Given this list of marker genes Naglu, Fgfr2, B4galnt1, Fgf8, Taf10, Pkdcc, Intu, Lrp4, Kdf1, Med31, Gli2, Wnt7a (NCBI Gene Id 22421), Nfia, Bmp4, Psen2, Rax, Wdr19, Hottip (NCBI Gene Id 791364), Cyp26b1 (cytochrome P450, family 26, subfamily b, polypeptide 1), Alx1 (NCBI Gene Id 216285), Nog, Wnt3, Ift172, Smoc1, Megf8, Ctnnb1, Aff3, Npr2, Ttbk2, Pbx1 (pre B cell leukemia homeobox 1), C2cd3, Bmpr2, Fgf10 (fibroblast growth factor 10), B3glct, Fbxw4, Rc3h2, Iqce, Cibar1, Gpc3, Fgfr1, Pcnt, Smarca4 (NCBI Gene Id 20586), Alx3, Grem1, Col6a1, Tmem231, En1, Traf3ip1, Fermt2, Ift52, Rspo4, Mbnl1, Tgfb2, Itgb4, Hoxc11, Ark2c, Gja5, Bax, Rspo2, Mir124a-1, Prickle1, Fuz, Dkk1, Rpgrip1l, Cplane1, Gdf5, Wnt5a, Ift80, Kremen2, Lmx1b, Ihh, Gnaq, Mir23a, Osr1, Map3k20, Mosmo, Gnas, Errfi1, Notch2, B9d1, Kat2a, Rarb, Idua, Hoxd11, Sp8, Zbtb16, Kat2b, Msx1, Hdac1 (NCBI Gene Id 630524), Fras1, Bbs7, Scx, Itga6, Tbx3, Comp, Ece1, Med1, Col3a1, Nipbl, Sulf1, Dlx6, Gna12, Hoxa11, Acd, Znrf3, Lrp6, Asph, Sall4 (NCBI Gene Id 99377), Rspo3, Hoxd9, Tbx2, Tbx5, Hoxa10, Cacna1c, Psen1, Dlx5, Gja1, Cplane2, Bak1, Ror2, Tfap2b, Plxna2, Osr2, Shh, Enpp1, Slc39a3, Pitx1, Sall1, Tfap2a, Sfrp2, Rarg, Gas1, Fbn2, Mecom, Ptch1, Bcl2l11, Bmp7, Ext1, Sox9, Col2a1, Hoxa9, Irf6 (NCBI Gene Id 98477), Kremen1, Dync2h1, Sall3, Mks1 (MKS transition zone complex subunit 1), Hnf1a, Twist1, Sema3c, Runx2, Lmbr1, Ift140, Ski, Lrp5, Prrx2, Atp7a, Atrx, Reck (NCBI Gene Id 53614), Tbx4, Msx2, Slc7a11, Ift122, Sik3, Sp9, Tmem107 (transmembrane protein 107), Dicer1, Hoxd10, Hotair, Foxn1, Fgf4, Prrx1, Prkab1, Hand2, Tulp3, Meox2, Rab23, Ift88, Hoxc10, Grhl2, Hdac2, Vps54, Chd7, Alx4, Hoxd13, Tbc1d32, Pbx2, Wnt9a, Galnt3, Mycn, Wdpcp, Slc39a1, Evx2, Pias4, Bpnt2, Bmpr1a, Lnpk (NCBI Gene Id 99060), Chst11, Rara, Spg21, Hoxa13, Hoxd12, Shox2, Rdh10, Fmn1, Pitx2, Fzd6, Zic3, Smad4, Gli3, Trp63, Notch1, Hoxc13, Pcsk5, Crabp2, Lef1, Fgf9, Aldh1a2, Dmd, Flvcr1, Large1, Zfp219, Frem2, here is a description of the gene set: Mouse Gene Set: GOBP_APPENDAGE_DEVELOPMENT species: Mus musculus The process whose specific outcome is the progression of an appendage over time, from its formation to the mature structure. An appendage is an organ or part that is attached to the trunk of an organism, such as a limb or a branch.